The following is a description of a gene set: Receptors directly transcriptionally regulated by MECP2 include glutamate receptor GRIA2, NMDA receptor subunits GRIN2A and GRIN2B, opioid receptors OPRK1 and OPRM1, GPRIN1, MET, and NOTCH1. Channels/transporters regulated by MECP2 include TRPC3 and SLC2A3. MECP2 also regulates transcription of FKBP5, involved in trafficking of glucocorticoid receptors and is implicated in regulation of expression of SEMA3F (semaphorin 3F) in mouse olfactory neurons. In zebrafish, Mecp2 is implicated in sensory axon guidance by direct stimulation of transcription of Sema5b and Robo2. MECP2 may indirectly regulate signaling by neuronal receptor tyrosine kinases by regulating transcription of protein tyrosine phosphatases, PTPN1 and PTPN4. species: Homo sapiens Reactome Pathway: MECP2 regulates neuronal receptors and channels part of: Transcriptional Regulation by MECP2, and this is the list of marker genes: GRIA2, OPRK1, TRPC3, GRIN2A, SIN3A, GPRIN1, SLC2A3, HDAC2, PTPN4, MET, OPRM1, FKBP5, CREB1, PTPN1, MECP2, HDAC1, NOTCH1, GRIN2B